Given this list of marker genes COL5A2 (collagen type V alpha 2 chain), NBEA, STK17A, LINC02604, SCML1, GPRASP1, AMN1, TTC28, SLC11A2, ROBO3, CA6, CADPS2, ZNF780B, CEP41, NPAS2, PLAG1, TOM1L2, TBC1D32, ANKRD36BP2, LRRN3, DSC1, SCML2, AIF1, CHMP7, ZNF496, DDR1, GAL3ST4, KCNQ5, ADGRA3, TUG1, TLE2, APBB1, SCARB1, KRT18, AEBP1, SNRPN, TMEM198B, STAP1, ZNF563, NSUN5, AGRN (agrin), TARBP1, RNF227, TMIGD2, NPM3 (NCBI Gene Id 63295), BTBD3, OBSCN-AS1, PCED1B, EFNA1, PDE9A, ZNF546, SPPL2B, SERTAD2, ALG10B, CD248 (CD248 molecule), LEF1-AS1, KLHL13, MEF2A, TMEM272 (transmembrane protein 272), PHGDH (NCBI Gene Id 94672), SIAH1, PLLP, ADGRL1, EEA1, ENGASE, TMEM220, USP44 (NCBI Gene Id 84101), SNPH, SNORD104, TMEM170B, BEND5, MRPL45P2, CIAPIN1, TGFBR2, CRLF3, GPRASP2, EDAR, BNIP3L, SFXN2, KRT2, SATB1, SERTM1, MZF1, MPP7 (MAGUK p55 scaffold protein 7), ZMYND8, TMEM263, PDE3B, MIR600HG, SNX9, PDCD4-AS1, CD55, ZBTB18, SETD1B, CHML, REG4, HIPK2, ZNF229, PDE7B, LAGE3P1, ZFTRAF1, POLR1HASP, KLHDC1, PITPNM2, PKIG, TAF4B, ABLIM1, PADI4, ZNF662, MPP1, PLA2G12A, FCGRT, EXPH5, SLC25A37, CLCN5, PIK3CD, DNTT, SLC25A25-AS1, LINC02175, MANSC1, CAMK4, METAP1D, HSF2, RNF175, CHI3L2, ZC4H2, NDC1, ZNF516, TMEM41B, PCSK5, VPS52, TIMP2, NUDT17, PECAM1, ME3, RHPN2, SH3RF3, UBE2E2, NDFIP1, PTPRK, SCAI, KCTD3, GNAI1, KRT72, NET1, MIR101-1, ACER1, PDK1, SFMBT2, PRRT1, MAML2, PRKCQ-AS1, NUCB2, MALL, GP5, NAA16, PIGL, BACH2, MYB, HEMGN, DNHD1 (NCBI Gene Id 387750), RGS10, MEST, PRXL2A, MLXIP, SREBF1, LMLN, RNF157-AS1, SNHG32, KLF3-AS1, RIN3, RETREG1, SLC29A2, IGIP, ZNF182, NUDT12, GPR160, CENPV, ARMCX2, ITGA6 (NCBI Gene Id 3655), RAPGEF6, GPRC5B, PIK3IP1, PDE7A, IGF1R, SERPINE2, SORCS3, SLC2A11, SMPD1, ZNF506, TSPAN3, KLHL24, PJVK, KRT73, APBA2, PXYLP1, here is a description of the gene set: Microarray deconvolution is a technique for quantifying the relative abundance of constituent cells in a mixture based on that mixture's microarray signature and the signatures of the purified constituents. It has been applied to yeast and other systems but not to blood samples. Here we test the ability of this technique to determine the fractions of subsets of memory T cells in peripheral blood mononuclear cell (PBMC) samples. Genes up-regulated in comparison of naive T cells versus memory T cells. Human Gene Set: GSE11057_NAIVE_VS_MEMORY_CD4_TCELL_UP from publication Abbas AR, Wolslegel K, Seshasayee D, Modrusan Z, Clark HF (PMID 19568420) species: Homo sapiens